Given this list of marker genes Dusp7, Dusp13b, Dusp9, Dusp4, Dusp26, Dusp14, Dusp12, Dusp10, Dusp6, Dusp15, Dusp5, Dusp22, Dusp8, Dusp3, Dusp16, Ppm1f, Eya3, Epm2a, Dusp21, Dusp1, Dusp19, Dusp18, Dusp2, Dusp23, Dusp29, Mtmr3, Styxl2, here is a description of the gene set: Mouse Gene Set: GOMF_PROTEIN_TYROSINE_SERINE_THREONINE_PHOSPHATASE_ACTIVITY studied in species Mus musculus Catalysis of the reactions: protein serine + H2O = protein serine + phosphate; protein threonine phosphate + H2O = protein threonine + phosphate; and protein tyrosine phosphate + H2O = protein tyrosine + phosphate.